Given this list of marker genes CGB3, CD44, CDH3, CTSB, PROS1, CRIP2, SCEL, TGFBI, TNC, SRPX, IGFBP6, PLAUR, SMAD6, CXCL2, ITGB4, SPP1, STS, GALNT6, SPARC, STEAP3, GAS2L1, COL13A1, PLAT, CDKN1A, S100A4, CEACAM1, LOXL2, CLIC3, KRT81, CFI, ST6GAL1, SSBP2, LEPR, KLRC1, ACOX2, COL6A1, ATP2B4, TGM2, here is a description of the gene set: from publication Huang G, Eisenberg R, Yan M, Monti S, Lawrence E, Fu P, Walbroehl J, Löwenberg E, Golub T, Merchan J, Tenen DG, Markowitz SD, Halmos B (PMID 18593902) Human Gene Set: HUANG_FOXA2_TARGETS_DN species: Homo sapiens The forkhead transcription factor hepatocyte nuclear factor 3beta (HNF3beta) is essential in foregut development and the regulation of lung-specific genes. HNF3beta expression leads to growth arrest and apoptosis in lung cancer cells and HNF3beta is a candidate tumor suppressor in lung cancer. In a transcriptional profiling study using a conditional cell line system, we now identify 15-PGDH as one of the major genes induced by HNF3beta expression. 15-PGDH is a critical metabolic enzyme of proliferative prostaglandins, an antagonist to cyclooxygenase-2 and a tumor suppressor in colon cancer. We confirmed the regulation of 15-PGDH expression by HNF3beta in a number of systems and showed direct binding of HNF3beta to 15-PGDH promoter elements. Western blotting of lung cancer cell lines and immunohistochemical examination of human lung cancer tissues found loss of 15-PGDH expression in approximately 65% of lung cancers. Further studies using in vitro cell-based assays and in vivo xenograft tumorigenesis assays showed a lack of in vitro but significant in vivo tumor suppressor activity of 15-PGDH via an antiangiogenic mechanism analogous to its role in colon cancer. In summary, we identify 15-PGDH as a direct downstream effector of HNF3beta and show that 15-PGDH acts as a tumor suppressor in lung cancer. Genes down-regulated in H358 cells (lung cancer) by inducible expression of FOXA2 in a Tet-off system.